Given this list of marker genes Kcnk12, Kcnk16, Kcnk18, Kcnk5, Kcnk3, Kcnk4, Kcnk6, Kcnj12, Kcnj2, Kcnj14, here is a description of the gene set: electronically inferred by orthology from the curated human pathway This event has been computationally inferred from an event that has been demonstrated in another species.<p>The inference is based on the homology mapping from PANTHER. Briefly, reactions for which all involved PhysicalEntities (in input, output and catalyst) have a mapped orthologue/paralogue (for complexes at least 75% of components must have a mapping) are inferred to the other species. Reactome Pathway: Phase 4 - resting membrane potential species: Mus musculus part of: Cardiac conduction